Given this list of marker genes Hspd1, Tlr4, Cd14, Tril, Ly96, here is a description of the gene set: A multiprotein complex that consists of at least three proteins, CD14, TLR4, and MD-2, each of which is glycosylated and which functions as a lipopolysaccharide (LPS) receptor that primes the innate immune response against bacterial pathogens. species: Mus musculus Mouse Gene Set: GOCC_LIPOPOLYSACCHARIDE_RECEPTOR_COMPLEX